The following is a description of a gene set: Mouse Gene Set: GOBP_DENDRITIC_CELL_CYTOKINE_PRODUCTION species: Mus musculus Any process that contributes to cytokine production by a dendritic cell., and this is the list of marker genes: Tlr2, Ticam1, Mavs (mitochondrial antiviral signaling protein), Slamf9, Tlr4, Clec7a, Plcg2, Jak3, Ddx21, Rigi, Ddx1, Nod2, Scimp, Tlr9, Tlr3, Bst2, Dhx36, Kit